Given this list of marker genes Mocos, Mocs3, Mocs2, Nfs1, Mocs1, Gphn, here is a description of the gene set: Mouse Gene Set: GOBP_PROSTHETIC_GROUP_METABOLIC_PROCESS studied in species Mus musculus The chemical reactions and pathways involving a prosthetic group, the non-amino acid portion of certain protein molecules. Prosthetic groups may be inorganic or organic and are usually required for the biological activity of the protein.